Given this list of marker genes KCND2, KCND3, KCNIP3, KCNIP1, KCND1, KCNIP4, KCNIP2, here is a description of the gene set: Reactome Pathway: Phase 1 - inactivation of fast Na+ channels part of: Cardiac conduction Phase 1 of the cardiac action potential is the inactivation of the fast Na+ channels. The transient net outward current causing the small downward deflection (the "notch" of the action potetial) is due to the movement of K+ and Cl- ions. In pacemaker cells, this phase is due to rapid K+ efflux and closure of L-type Ca2+ channels (Park & Fishman 2011, Grant 2009). species: Homo sapiens